The following is a description of a gene set: Genes amplified and up-regulated more than twofold in at least two out of 10 pancreatic cancer cell lines studied. Human Gene Set: HEIDENBLAD_AMPLIFIED_IN_PANCREATIC_CANCER DNA copy number alterations are believed to play a major role in the development and progression of human neoplasms. Although most of these genomic imbalances have been associated with dysregulation of individual genes, their large-scale transcriptional consequences remain unclear. Pancreatic carcinomas frequently display gene copy number variation of entire chromosomes as well as of chromosomal subregions. These changes range from homozygous deletions to high-level amplifications and are believed to constitute key genetic alterations in the cellular transformation of this tumor type. To investigate the transcriptional consequences of the most drastic genomic changes, that is, genomic amplifications, and to analyse the genome-wide transcriptional effects of DNA copy number changes, we performed expression profiling of 29 pancreatic carcinoma cell lines and compared the results with matching genomic profiling data. We show that a strong association between DNA copy numbers and mRNA expression levels is present in pancreatic cancer, and demonstrate that as much as 60% of the genes within highly amplified genomic regions display associated overexpression. Consequently, we identified 67 recurrently overexpressed genes located in seven precisely mapped commonly amplified regions. The presented findings indicate that more than one putative target gene may be of importance in most pancreatic cancer amplicons. species: Homo sapiens from publication Heidenblad M, Lindgren D, Veltman JA, Jonson T, Mahlamäki EH, Gorunova L, van Kessel AG, Schoenmakers EF, Höglund M (PMID 15688027), and this is the list of marker genes: ECH1, TRIM26, ETNK1, PSMC4, C2CD5, TSPAN12, TM7SF3, ST8SIA1, HCG4, HBS1L, PAF1, SMURF1, FGFR1OP2, REP15, CBLL1, FAR2, ZNF780A, CCDC91 (NCBI Gene Id 55297), ERGIC2 (ERGIC and golgi 2), PAK4, AKT2, FBL, DLL3, MDFIC, TBC1D31, CYC1, DLD, MAL2, PON2, PPFIBP1, TLK2, ATF6B, CAPN12, TMTC1 (NCBI Gene Id 83857), CMAS, CYRIB, PTK2, BHLHE41, RASSF8, SUPT5H, SSPN, ITPR2, BET1, TMEM65, AKAP9, LRATD2, METTL2A, CCN3, BCAT1, MAF1, DSCC1, EID2, MED21, KLHL42, MRPS12 (mitochondrial ribosomal protein S12), COMMD5, ATAT1